The following is a description of a gene set: studied in species Mus musculus Genes up-regulated in LSK cells (bone marrow) as a function of a QTL for the size of hematopoietic stem cell (HSC) population: comparison of congenic B.D. chr3 (BD, large HSC size) vs parental B6 strain (tiny HSC size). Mouse Gene Set: LIANG_HEMATOPOIESIS_STEM_CELL_NUMBER_LARGE_VS_TINY_UP We mapped quantitative trait loci that accounted for the variation in hematopoietic stem cell (HSC) numbers between young adult C57BL/6 (B6) and DBA/2 (D2) mice. In reciprocal chromosome 3 congenic mice, introgressed D2 alleles increased HSC numbers owing to enhanced proliferation and self-renewal and reduced apoptosis, whereas B6 alleles had the opposite effects. Using oligonucleotide arrays, real-time PCR and protein blots, we identified latexin (Lxn), a gene whose differential transcription and expression was associated with the allelic differences. Expression was inversely correlated with the number of HSCs; therefore, ectopic expression of Lxn using a retroviral vector decreased stem cell population size. We identified clusters of SNPs upstream of the Lxn transcriptional start site, at least two of which are associated with potential binding sites for transcription factors regulating stem cells. Thus, promoter polymorphisms between the B6 and D2 alleles may affect Lxn gene expression and consequently influence the population size of hematopoietic stem cells. from publication Liang Y, Jansen M, Aronow B, Geiger H, Van Zant G (PMID 17220891), and this is the list of marker genes: Hspa4, Ltv1, Gtf3a, Tmem141, Icam2, Pttg1, Prtn3, Gng12, Rasgrp2, Cdkn3, Itgb1bp1, Arhgap9, Tlr6, Jkamp, Msr1, Slfn2, Bex6, Tmem183a (NCBI Gene Id 75635), F2rl3 (NCBI Gene Id 14065), S100a6, Gnb4, Gba1, Rps4l, Elovl2, Fads1, Pgam1, Gcat, Il1r1, Smim7, Serpine2, Tuba1a, St6galnac4, Dio2, Lrrn1, Nlrx1, Lyz2, H2-DMb1, Saraf, Fcer1a, Fkbp1a, Fkbp11, Manf